The following is a description of a gene set: species: Homo sapiens It is still unclear how ADAR 1 and ADAR 2 proteins form the editosomes with the target RNA. Other components of these editosomes for A to I editing are unknown. <BR> Reactome Pathway: Formation of editosomes by ADAR proteins part of: mRNA Editing: A to I Conversion, and this is the list of marker genes: ADAR, ADARB1